Given this list of marker genes NCOA2, CIART, MTOR, NAGLU, ZFHX3, KCND2, ANKFN1, MTA1, NCOR1, ID2, USP2 (ubiquitin specific peptidase 2), PLN, ROGDI, PTEN, MC3R, EGR1, here is a description of the gene set: Human Gene Set: GOBP_LOCOMOTOR_RHYTHM species: Homo sapiens The rhythm of the locomotor activity of an organism during its 24 hour activity cycle.